The following is a description of a gene set: This event has been computationally inferred from an event that has been demonstrated in another species.<p>The inference is based on the homology mapping from PANTHER. Briefly, reactions for which all involved PhysicalEntities (in input, output and catalyst) have a mapped orthologue/paralogue (for complexes at least 75% of components must have a mapping) are inferred to the other species. part of: Extra-nuclear estrogen signaling studied in species Mus musculus Reactome Pathway: Estrogen-dependent nuclear events downstream of ESR-membrane signaling electronically inferred by orthology from the curated human pathway, and this is the list of marker genes: Cdkn1b, Xpo1